Given this list of marker genes LZTFL1, ACP5, BPTF, CFI, TNFSF12, MKKS, ELANE, MEG3, TAF4, DNAAF2, RFXANK, ZEB2, CD247, DNAAF4, NFKBIA, NELFA, WAS, CD3G, AP3B1, RAC2, UNC119, PGM1, APC2, VPS37D, CREBBP, SYK, MED12 (mediator complex subunit 12), ADAT3, DNAH9, AIRE, AK2, RAG2, DLX4, SPI1, RFC2, SDR9C7, CCDC47, WDPCP, ABCC6, CLIP2, HIRA, AGA, FRAS1, DLK1, LIG4, H4C3, FBXO11, RREB1, DAW1, RNU4-2, ODAD3, EP300, TGM1, GNPTAB (NCBI Gene Id 79158), EYA1, ALOXE3, PIK3R1, CDH1, RSPH3, DNAAF6 (NCBI Gene Id 139212), MAP3K7, IFT172, CD3D, SNX10, TLK2, STX1A (NCBI Gene Id 6804), RTL1, TNRC6B, KIF15, TCIRG1, FCGR3A, IDUA, ATN1, IL17RA, CDC42BPB, DNAL1, NAA10, COBLL1, GJB2, PCYT1A, DNAAF5, CFAP418, MSX1, GNS, CFAP74 (NCBI Gene Id 93196), ELN, GNB2, ALMS1, LRBA, NEK10, SLC37A4, OCRL, WDR26, TMCO1, FGF3, SHARPIN, CTLA4, USP26, SLC25A12, TLR8, NIPAL4, CYBA, SMARCD2, BAZ1B, RSPH1, NFIX, SETBP1, DPP9, MS4A1, ROR2, EIF4H, TAF1, KDM6A, METTL27, DNAI1, IL6ST, ENPP1, CYBB, NFKB2, PIGG, DPF2, KAT6A, STAG2, TBX1, BBS2, ICOSLG, CYP4F22, TNFRSF13B (TNF receptor superfamily member 13B), CFAP300, FZD2 (NCBI Gene Id 2535), ICOS, IL2RG, KMT5B, POLR3A, IL7R, CDCA7, ZNF341, BBS1, SLC35C1, NCF4, DOCK8, PHIP, ZMYND10, PRTN3, GAS8, C1QB, ADA2, DNAH1, TCF3, IQSEC2, FLII, COL11A1, FOCAD (focadhesin, NCBI Gene Id 54914), SCAPER, TNFSF11, PIK3CD (NCBI Gene Id 5293), RELB, TFE3, BBS12, H4C5, GUSB, HLA-DPA1, RNU4ATAC, STIM1 (NCBI Gene Id 6786), SLC39A7, DRC1, GJB6, COMT, BBS10, POLR1D, SRY, NCKAP1L, CCDC65, COL2A1, GRHL3, MGP, DCLRE1C, ARHGAP29, JMJD1C, SCLT1, RFXAP (regulatory factor X associated protein), NXN, DEAF1, BLNK, TTC8, ARL6, DNAAF11, NOTCH3, BBIP1, ODAD2, DYRK1A, FLNA, NFKB1, KANSL1, CD81, SMARCA4, RAD21, BAP1, OFD1, CCNO, GTF2I, IKBKB, DLG1, SPEF2, GATA2, TAP1, KMT2A, CD79B, NBN, RIC1, TMEM270, TFAP2A, FKBP6, CD3E, SIX5, CFAP298, FGFR3, NKX2-1, CD79A, EYA4, RPL11, PDGFRA, EFTUD2, CXCR4, SH3KBP1, IDS, PRKCD, ADA, TGDS, ARHGEF38, DDB1, CR2, AHDC1, PLCG2, ARVCF, FOXN1, ANAPC1, RAP1B, RPGR, DNAAF3, SIN3A, BLM, POLR1A, SEC24C, CTBP1, GTF2IRD1, ODAD1, INSR (insulin receptor), CIITA, BMP4, LIG1, TBL2, NECTIN1, HEPHL1, CFAP45, IFT74, FGFR2, PGM3, RAC1, DNAI2, DDR2, FOXL1, THRB, RAI1, GTF2IRD2, NIPBL, CYBC1, NSD2, IGHG2, CCDC40, ANKRD11, CEP19, RNF168, IGHM, NCF1, DNAJC30, PSMD12, USB1, KMT2D, DOCK11, ANKH, DOCK2, GAS2L2, RSPH9, LETM1, MAGT1, PNP, SULT2B1, GLRA2 (NCBI Gene Id 2742), C4B, TBX4, LRRC8A, HLA-DPB1, MAN2B1, HYDIN, SPTBN1, SPAG1, CFAP221, PIGH, CD19, LIMK1, LRRC56, SETD2, STK36, JAGN1, DHCR7, SLF2, IGLL1, RSPH4A, ABCA12, BBS5, MAPK1, SDCCAG8, DNAAF1, DNAH11, CFAP52, UBB, TTC12, TNFRSF13C, TAOK1, RFX5, MCIDAS, NME8, TPP2, CPLX1, DNAJB13, JAK3, CORO1A (coronin 1A), NSUN2, COG1, ALOX12B, PIK3CG (phosphatidylinositol-4,5-bisphosphate 3-kinase catalytic subunit gamma), POGZ, NPHP1, CARMIL2, IL6R, NSD1, CCDC39, TRIM32, HYAL1, CEP290, WIPF1, IKBKG, BTK, PTEN, NCF2, MLXIPL, BBS9, SEC61A1, BCOR, TP73, RUNX2, PSMB8, IFT27, PRKAR1B (NCBI Gene Id 645590), IL11RA, IRF2BP2, MNS1, RNF2, FOXJ1, SMG9, BBS7, COL1A2, BBS4, COL1A1, CEBPE, IL21R (NCBI Gene Id 50615), IGKC, DNAH5, CBLB, UFD1, FMR1, GDF6, PTPN22, NME5, MKS1 (MKS transition zone complex subunit 1), CD4, TRAC, STAT3, CCDC103, IRF6, LBR, PDCD1, ODAD4, G6PC3, POU3F4, LIPN, NOG, CLCN7, ASPRV1, A2ML1, FOXP1, AGR2 (anterior gradient 2, protein disulphide isomerase family member), BUD23, GP1BB, SRCAP, CD28, SIX1 (SIX homeobox 1), RAG1, TP63, IL2RB, here is a description of the gene set: An abnormality of the morphology or structure of the middle ear. Abnormal middle ear morphology species: Homo sapiens Human Gene Set: HP_ABNORMAL_MIDDLE_EAR_MORPHOLOGY